Given this list of marker genes Sema6a (NCBI Gene Id 353045), Cpeb1, Scgb1b7, Gdi1, Scgb1b12, Qki, Cpn2, Eif2s2, Rbpj, Ptbp2, Dsel, Map3k9, Dynap, Zfx, Dyrk3, Sos1, Mast3, Teddm1b, Triobp, Tle1, Trak1, Hspb8, Nxf2, Negr1, Fgf14, Dcaf17, C2cd6, Camta1 (NCBI Gene Id 75679), Fmr1, Lrrc28, Pknox1, Cyp2g1, Sec22b, Scgb1b20, Mrps30, Zfp275, Scgb1b29, Lingo2, Rbl1, Tceanc, Igf1, Cdk14, Amn1, Dhx16, Rab18, Kif26b, Cbfa2t3, Ap1s1, here is a description of the gene set: Mouse Gene Set: MIR_679_3P Genes predicted to be targets of miRBase v22 microRNA mmu_miR_679_3p in miRDB v6.0 with MirTarget v4 prediction scores > 80 (high confidence targets). from publication Chen Y, Wang X (PMID 31504780) studied in species Mus musculus